The following is a description of a gene set: from publication Belyaev NN, Biró J, Athanasakis D, Fernandez-Reyes D, Potocnik AJ (PMID 22581009) Human Gene Set: GSE24142_ADULT_VS_FETAL_DN3_THYMOCYTE_UP Genes up-regulated in comparison of adult DN3 thymocytes versus fetal DN3 thymocytes. Development of T-cells provides a unique opportunity to study cell-fate determination due to the accessability and the well defined stages of developmental stages. In order to understand the genetic programs underlying fetal and adult T‑cell fate specification we subjected highly purified fetal and adult T-cell progenitor populations to a genome‑wide transcriptional analysis. The aim was to identify molecular elements that govern T-cell fate specification as a whole but ultimately to isolate elements that were specific for a given population in a specific developmental window. studied in species Homo sapiens, and this is the list of marker genes: SLC44A1, MED1, GBP6, MARVELD1, TEF, CUX1, ZNF746, ATP6V0A2, PCK2, ZNF280C, ALCAM, HBP1, CREBRF, SQOR, GNB4 (NCBI Gene Id 59345), PTGER4, EZH1, TRIP6, CUEDC1, UCHL1, CDC37L1, CERS2, LY75, NRIP1, CLIP1, FGD1, FXYD5, L2HGDH, RNASEH1, SLC35A1 (NCBI Gene Id 10559), ZNF703, SYTL4, TACC2, NLGN2, ZFYVE16, STAP1, EPB41L4B (NCBI Gene Id 87974), LAPTM4B (lysosomal protein transmembrane 4 beta), RAPGEF6, LY6D, LPIN1, TRAT1, GAB1, DDIT4L, NT5C2, MPP4, RBBP8, ATP2A1, DDHD2, ANXA4, ANKRD28, HMGN3, CCNH, SUN2, EHD3, RPL22, AP3S1, CIPC, SHMT1, NR3C1, TAPBP, STK17B, HYCC2, SLC29A2, RAB6B, NSG1, KIF2A, MDFIC, PTGR3, SYNCRIP, TIFA, PRKACB, CMTM3, LCORL, ANXA2, ZFP36L2, PURB, SACS, TET1, SRGAP3, PPARGC1B, RAB10, ZNF131, HES5, MECP2, RSAD2, PTPN22, PRPSAP2, HKDC1, TNS1, RCN1, SLC30A4, MYO1C, QPCT, BCL2L2, PCNP, THRA, OSBPL1A (NCBI Gene Id 55097), RNF220, LARS1, INPP5K, ADGRD1, TP53INP1, SFMBT2, ZFX, FAM117A, ADCY3, HLA-B, MAT2A, NR1D2, SMAD1, MAP4K3, PARD6G, PTEN, NT5C3A, ZEB2, GPHN, SELENON, GOSR1, DENND4C, LGALSL, TCF4, RPL23, UVRAG, CUL9, SYNJ2, TSC22D3, ABCG2, PIP4K2A, IRAK1, GID4, ISOC1, ARMCX1 (armadillo repeat containing X-linked 1), FGF13, PRDM5, TIA1, CD28, TRIM34, IL27RA (NCBI Gene Id 9466), LRP1, HLA-DMA, PATJ (NCBI Gene Id 10207), UBA7, RB1CC1, FRMD6, ERBIN, AZI2, B3GNT5, TNFRSF18, DBP, ICA1, PELI2, CD84 (NCBI Gene Id 8832), TESC, IGHM, TIPARP (TCDD inducible poly(ADP-ribose) polymerase), REPIN1, ICE2, IL11RA, NFIX, NAMPT, PARP8, INSL6, ZMYM5, JADE1, TOPORS, PURA (NCBI Gene Id 5813), TMEM71, RAB3GAP2, MS4A6A, CD96, REST, MAN1A1, LPIN2, CNOT4, WLS, PIPOX, CDKN1A, M6PR, DIO2, NEFH, CCDC117, ST7, MST1R, IRF1, ARAF, CEBPG, P2RX4, HLA-C, CAMKV, PITPNC1, DDX60, BCL3, DHX58, MBNL1, EIF4E3, CASP1, DMAC2L, UBR5, DGKG